Given this list of marker genes NAAA, CYSLTR2, ZFC3H1, SETDB2, PAXBP1, NCOA6, ZFAND2A, EIF2B2, NIPBL, WDFY2, APPL2, VDR, DRAM2 (DNA damage regulated autophagy modulator 2), PSAP, SHROOM3, SPECC1 (NCBI Gene Id 92521), ADAMTSL5, ZNF362, C9orf85, TIMM23, RPS11, VPS26C, SIM1, HINFP, SIK2, ZBTB1, RTL5, FAM91A1, DEF8, ATP10D, ARID5B, PHKG2, PATL2, CSTB, MORN5, ALDOB, CDS2, BSCL2, RPL22, AKT1S1, N6AMT1, VSX1, TAF5L, FECH, EXTL2, SDK1, SLC35A4, SLC26A1, GPNMB, MRTFB, RNMT, DNAJC12, RPS6KB2, CCDC82, CDCP1, RPL27, PDZRN3, SUSD2, ENSA, MOCOS, PCDHB15, ESPN, CRYZ, TFDP2, C8orf82, TIAM1, PSMD8, NCBP3, SLC2A6, C11orf68, WDSUB1, DPY19L3, PITPNM1, RSPRY1, DKK2, ANXA3, RLN1, TBC1D23, FGFR1OP2, FAM199X, RUFY1, GLB1, MED20, STMN4, CD200R1, WDR82, LGALS4, PIP4P2, FAM177A1, TUBA1A, ZBTB14, SCAMP2, ATP6V0E1, STXBP3 (NCBI Gene Id 730947), SH3BP5L, PPP1R21, RAPGEFL1, LTN1, RHOBTB2, ITGAX, KRTAP3-3, CREG2, GBE1, LY96, AP1G1, ZNF687, HCCS, AEBP2, ZSCAN12, BAD, MAP4K4, PTPN1, SLC17A6, SLC6A15, IFT140, MT2A, SIT1, PMS2, NPB, THPO, PPIP5K1, VDAC2, PSTPIP2, EXT1, LACC1, SLCO3A1, UPP1, PCM1, ATCAY (ATCAY kinesin light chain interacting caytaxin), SYPL1, TMEM26, DACH2, DDX19B, MKRN1, RPS6KA5, SNTB1, SPX, GYG1, UBE2B, PTPN13, LEPROT, RALGPS2, RSU1, SH3PXD2A, SLC25A12, MLYCD, AKAP7, APOA2, UBXN4, PCCA, NTF3, SELENBP1, GPC2, MCM7, SEC24A, GNAS, PPP3R1, RTL8B, CHD2, BAMBI, FAM219B, CCDC136, REV1, TMEM219, BCL2L15, ACSL4, LRRK2, PSTK, XXYLT1, AKR1C3, SNHG32, FAM118A, MITF, DENND1A, JCHAIN (NCBI Gene Id 3512), WDR6, ZKSCAN8P1, HCK, DCTN5, JADE1, MFSD10, GABARAP, DNAJB12, TDRD1, CHP1, CFH, TTC4, AHRR (NCBI Gene Id 57491), CCK, GRIK1, CCR3, GNAI3, FGF17, ADGRE1, SLC27A1, PARK7, LAMC2, SLK, HSD17B11, here is a description of the gene set: After activation, CD4+ helper T (Th) cells differentiate into distinct effector subsets. Although chemokine (C-X-C motif) receptor 5-expressing T follicular helper (Tfh) cells are important in humoral immunity, their developmental regulation is unclear. Here we show that Tfh cells had a distinct gene expression profile and developed in vivo independently of the Th1 or Th2 cell lineages. Tfh cell generation was regulated by ICOS ligand (ICOSL) expressed on B cells and was dependent on interleukin-21 (IL-21), IL-6, and signal transducer and activator of transcription 3. However, unlike Th17 cells, differentiation of Tfh cells did not require transforming growth factor b (TGF-b) or Th17-specific orphan nuclear receptors RORa and RORg in vivo. Finally, naive T cells activated in vitro in the presence of IL-21 but not TGF-b signaling preferentially acquired Tfh gene expression and promoted germinal-center reactions in vivo. This study thus demonstrates that Tfh is a distinct Th cell lineage. Genes down-regulated in comparison of Th1 cells versus Th17 cells. studied in species Homo sapiens Human Gene Set: GSE11924_TH1_VS_TH17_CD4_TCELL_DN from publication Nurieva RI, Chung Y, Hwang D, Yang XO, Kang HS, Ma L, Wang YH, Watowich SS, Jetten AM, Tian Q, Dong C (PMID 18599325)